Given this list of marker genes SNAI2, TSC22D1, CEBPA, MIR221, MIR222, here is a description of the gene set: Human Gene Set: GOBP_NEGATIVE_REGULATION_OF_HEMATOPOIETIC_STEM_CELL_PROLIFERATION Any process that stops, prevents or reduces the frequency, rate or extent of hematopoietic stem cell proliferation. species: Homo sapiens